The following is a description of a gene set: Mouse Gene Set: GOBP_POSITIVE_REGULATION_OF_CYTOPLASMIC_TRANSLATION species: Mus musculus Any process that activates or increases the frequency, rate or extent of cytoplasmic translation., and this is the list of marker genes: Paip1, Syncrip, Zcchc13, Lin28a, Dhx9, Dhx36, Ybx1, Hnrnpd, Pkm, Hnrnpu, Pabpc1, Piwil2, Igf2bp1, Csde1, Eef2, Cnbp (NCBI Gene Id 12785)